The following is a description of a gene set: Relationship between inflammation, COX-2 and EGFR species: Homo sapiens Human Gene Set: WP_RELATIONSHIP_BETWEEN_INFLAMMATION_COX2_AND_EGFR, and this is the list of marker genes: EGFR, PTGER4, PIK3CG, MAPK1, PTGER1, CYP19A1, KRAS, AKT2, PIK3CD, AKT1, PIK3CA, PIK3CB, PTGS2, PTGER2, NRAS, MAPK3, PTGER3, MMP1, HRAS, BRAF, AKT3, SRC, PTGES2 (prostaglandin E synthase 2), ESR1, PLA1A